The following is a description of a gene set: Cell types are named using anatomical and functional mnemonics prefixed by 'm' or'h' to indicate mouse and human respectively: OMTN, oculomotor and trochlear nucleus; Sert, serotonergic; NbM, medial neuroblast; NbDA, neuroblast dopaminergic; DA0-2, dopaminergic neurons; RN, red nucleus; Gaba1-2, GABAergic neurons; mNbL1-2, lateral neuroblasts; NbML1-5, mediolateral neuroblasts; NProg, neuronal progenitor; Prog, progenitor medial floorplate (FPM), lateral floorplate (FPL), midline (M), basal plate (BP); Rgl1-3, radial glia-like cells; Mgl, microglia; Endo, endothelial cells; Peric, pericytes; Epend, ependymal; OPC, oligodendrocyte precursor cells. Human Gene Set: MANNO_MIDBRAIN_NEUROTYPES_HSERT species: Homo sapiens from publication La Manno G, Gyllborg D, Codeluppi S, Nishimura K, Salto C, Zeisel A, Borm LE, Stott SRW, Toledo EM, Villaescusa JC, Lönnerberg P, Ryge J, Barker RA, Arenas E, Linnarsson S (PMID 27716510), and this is the list of marker genes: ZC2HC1A, CNTNAP4, CADM1, SLC18A2 (solute carrier family 18 member A2), PSD2, CHGA, MYCBP2, GRIA4, NELL1, SHANK3 (SH3 and multiple ankyrin repeat domains 3), CYP4X1, KLHL32, TSHZ2, CCSER1, MAP1B, CACNA1C, JAKMIP1, RALYL (NCBI Gene Id 138046), OLFM3, SMARCD3, LY6H, EEF1A2, SLC7A14, CACNA1B, CDKL2, GRM5, BTBD6, LMX1B, CHGB, NAPB, TMEM169, GAP43, EPB41L1, SMIM17, MTUS2, INA, PKIA, DMTN, VSNL1, NRXN1, LPCAT4, CRMP1, C22orf42, ASB2, COL5A2, RIMS1, NEGR1, GPRASP1, FGF13, KCNQ3, YWHAG, DPYSL3, BEX1, SLC35F3, MCF2, GCHFR, CAMK2N2, KCNIP4 (potassium voltage-gated channel interacting protein 4), AFF2, DNAJC12, TAFA5 (NCBI Gene Id 25817), DNAJC6, DNAJC5, NAP1L3, ATL1, SOX14, MAP1LC3A, AP3B2, CNTN4, NCDN, GATA2, CNGB1, SLC4A8, CGREF1, NDRG4, ZCCHC12, SCN7A (NCBI Gene Id 6333), SMPD3, GABRB2, TAFA1, NOL4, MYO5A, IL27RA, SLC9A6, OPN5, KLC1, L1CAM, PRKAR2B, SLC6A4, CACNA1A, TMEM151A, GLT8D2, TPPP, RASA4, SSTR2, PNMA8B, ICA1, SCN3A, GFOD1, RIPOR2, CD47, LPIN2, BOP1, AATK, MFSD6, MAOA, BASP1, GABRG2, INHBA-AS1, PAQR8, ATP2B2, SH3KBP1, SEZ6L2, SYT1, PDZD7, FGF14, LHFPL4 (LHFPL tetraspan subfamily member 4), PNMA2, GDAP1L1, DNM3, SLC6A1, CDH8, MTURN, SYN2, AK5, BRINP3, LRP1B, ATCAY, NALF1 (NCBI Gene Id 731895), GPR12, SLC4A3, SLC6A15, TRIM46, ZFHX2, SLC37A1, GRIP2, TRIM67, KCNC1, SLC12A5, ADCY1, RBFOX1, CASZ1, PTPRR, CA1, ERC2, PCDHA7, PCDH11X, SCN2A, SPOCK3, MSANTD3-TMEFF1, SYP, GATA3-AS1, GRIK2, POU2F2, SRRM4 (NCBI Gene Id 84530), CACNA1G, XKR6, PLCB1, SNORD116-29, OPTN, GATA3 (GATA binding protein 3), RTN1, PRKCZ, SH3GL3, PI4KA, USP27X, EMID1, SCN3B, ARFGEF3, TMEM14A, CELF6, SERINC1, LONRF2, KLHL29, FEV, THSD7B, PEG3, CEP126, PRKACB, CDRT4, CACNG8, PTPRM, APLP1, SPOCK2, SAMD14 (NCBI Gene Id 201191), RIMS4, PRKAR1B, PPFIA2 (NCBI Gene Id 8499), COMTD1, ADGRB1, GCH1, ABR, ACOT7, PRKCB, CCDC85A, SMIM18, SH3BP5, MLLT11, PLCXD3, ERC1, RBMS3, PAK6, ACSL6, CNIH2, SLC4A1, KIRREL3, ABLIM1, GNAL, CACNA1E, STMN4, PPFIA4, CRTAC1, CBLN2, CHRNA4, MEG3, NSG1, RAB9B, GABRB1, LRATD1, TRPV2, TNS1, CPNE7, TAFA2 (TAFA chemokine like family member 2), NRXN2, GRIA1, CSRNP3, DDC, STMN2, KIF5C, FBXL16, ZNF32, CDK5R1, DIRAS2, FKBP1B, CLCN4, PIGZ, DYNC1I1, CELF5, TAC1, DPF1, SNAP25, GPR176, VAT1L, TTC9B, CDH13, BRINP1, PSD, KIFC2, CDKN2D, ANK2, VSTM2A, TSPAN7 (tetraspanin 7), SEZ6, SPOCK1, APBA1, SYBU, GOT1, MMP24 (NCBI Gene Id 10893), DACT3, KCTD2, FAR2, TUBB4A, TENM2, GOLGA7B, SLITRK4, NSG2, RETREG1 (reticulophagy regulator 1), PNCK, ZFHX3, ACTL6B, AKR1C2, PLPPR2, CHCHD1, SCN9A, REEP1, SNX1, SVOP, PITPNC1, KCNK3, SPINT2, ARRB1, CELF4, GLRA2 (NCBI Gene Id 2742), CNTN1, MAPRE2, MCF2L (MCF.2 cell line derived transforming sequence like), GRM7, MARCHF1, SERPINI1, NAP1L5, PCDH9, RAB24 (NCBI Gene Id 53917), CD2, GNG2, ROBO2, CLVS1, MGAT4C, GPM6A, LHFPL3, GRIN3A, TMEM121B, RAB15, CPEB3, AKAP7, PPP2R2B, AKR1C1, HPCAL4, CAMK2B, OPCML, KSR2, RIMS2, MAPK8IP2, NCAM1 (NCBI Gene Id 4684), CHD5, SEMA3C, VGF, SLC8A2, QDPR, GABRG1, ELAVL2 (ELAV like RNA binding protein 2), PHACTR3, CCDC184, PDE11A, ENO2, SYT13, DOK6, TUBB3, JPH4, RFPL1S, GRIA2, PRRT4, GPR149, FSD1, SORCS3, YWHAH, STXBP1, HSPA12A, GPC3, LGI1, RNF112, RAB3B, XPR1, DCX, NFASC, RALGDS, B9D1 (NCBI Gene Id 27077), ANKRD44 (NCBI Gene Id 91526), LINGO1, SCG2, PFKP, EID2B, SNCA, CHODL, CHST1, UNC79, RUNDC3B, PCSK1N, JPH3, FNDC10, CELF3 (CUGBP Elav-like family member 3), FRMPD4 (FERM and PDZ domain containing 4), SYNGR3, GREM2, HS6ST3, ANO8, TPH2, SLC22A17, BAALC, ATP1A3, CTXN2, MAPRE3, PLCH2, RBFOX2, CPNE5, MEST, PRRT2, PPM1H, HBA1, MAP2K4, SLITRK1, MICOS10-NBL1, NCOA7, TMOD2, BTBD1, NKAIN2, UCHL1, PLXNC1, FRY, GRM8, HS3ST4, CALB1, ABHD17A, SLC24A3, RBFOX3, MAST1, PCDH7, PCDH19, CREG2, BEX5 (brain expressed X-linked 5), PLPPR5, RGS17, TMEM178B, KRT17, TMEM35A, C10orf95-AS1, FBLL1, ST8SIA3, TUBB2A, SCG5, ADAM22, GARNL3, NDFIP1, PLPPR3 (phospholipid phosphatase related 3), CPNE4, KANK4 (NCBI Gene Id 388637), PLPPR4, LMTK3, GPR26, GNG3, SEPTIN6, TARBP1, TMEM59L, RIMBP2, PGM2L1, FNDC9, THRA, BEX2, SBK1, YPEL2, SOX1, RASGRP2, CFAP276, LRFN5, ATP6V1A, UBE2E2, ZNF385D, PITRM1, GNAO1, NALCN, MAP7D2, KIT, GABBR2, RNF175, ASXL3, SNCG, NPTXR (neuronal pentraxin receptor), SNAP91, SYTL2 (synaptotagmin like 2), RUFY3, CTHRC1